The following is a description of a gene set: Mouse Gene Set: GOBP_REGULATION_OF_MICROGLIAL_CELL_ACTIVATION Any process that modulates the frequency, rate or extent of microglial cell activation. studied in species Mus musculus, and this is the list of marker genes: Hspa4, Trem2, Mmp8, Cst7, Stap1, Pparg, Atm, Cx3cl1, Nr1d1, Ctsc, Kcnn4, Tafa3, Syt11, Grn, Lrrk2, Ttbk1, Ldlr, Calhm2, Sphk1